The following is a description of a gene set: Catalysis of the cleavage of a flap structure in DNA, but not other DNA structures; processes the ends of Okazaki fragments in lagging strand DNA synthesis. Mouse Gene Set: GOMF_FLAP_ENDONUCLEASE_ACTIVITY studied in species Mus musculus, and this is the list of marker genes: Gen1, Slx1b, Mus81, Fan1, Exo1, Fen1, Dna2